The following is a description of a gene set: studied in species Homo sapiens This pathway serves as collection of reactions categorized as SLC-mediated transport of organic anions Reactome Pathway: SLC-mediated transport of organic anions part of: SLC-mediated transmembrane transport, and this is the list of marker genes: SLC13A3, SLC22A6, SLC25A11, SLC22A7, SLCO2A1, SLC44A5, SLCO1B3, SLCO3A1, SLC10A6, SLC5A8 (solute carrier family 5 member 8), SLC16A8, SLCO1A2, SLCO2B1, SLCO1B1, SLC25A1, AVP, SLC22A8, SLCO4A1, SLC16A2, SLC13A2, EMB, SLC25A10 (solute carrier family 25 member 10), SLCO4C1, SLC16A7, SLC5A7, SLC16A1, SLC44A1, SLC44A3, SLC22A12, SLC44A2, SLCO1C1, SLC17A5, BSG, SLC13A5, SLC5A12, SLC44A4, SLC22A11, SLC16A3